Given this list of marker genes FBXO31, SKA3, SYF2, DONSON, BRCC3, NBN, PLK3, ZW10, NABP2, MBTPS2, TIPIN, RAD9A, TREX1, CHEK2, FZR1, INIP, MSH2, ATF2, CLSPN, RPS27L, CCNB1, MAD2L2, LCMT1, MRNIP (NCBI Gene Id 51149), DUSP1, STK33, PLK1, DTL, MRE11, ZNF830, CDK5RAP2, INCENP, SPDL1, TAOK1, SKA1, TRIAP1, TPR, NUF2, CDK5RAP3, NAE1, BUB3, CHFR, BUB1B, SETMAR, UIMC1, WAC, GEN1, RFWD3 (ring finger and WD repeat domain 3), CDC6, ORC1, XPC, APC, PRAP1, CHEK1, RPA2, BRCA1 (BRCA1 DNA repair associated), BRSK1, IER3, TP53, KLHL22, CCND1, SPC25, ZNF207, CDK2, ATM, NABP1, HUS1B, CDC14B, AURKB, ZWILCH, EME2, ANAPC15, ATR, VPS4A, USP44, INTS3, BIRC5, MUC1, BABAM2, CENPF, SDE2, FANCD2, RBBP8, MAP3K20, BLM, ABRAXAS1, SPC24, RINT1, TICRR, RAD17, TAOK3, MAD2L1, KNL1, GIGYF2, MUS81 (MUS81 structure-specific endonuclease subunit), IK, TTK, MDC1, PRP4K, EME1, TAOK2, MAD2L1BP, NOP53, HUS1, ZWINT, NDC80, TRIM39, KNTC1, DYNC1LI1, FOXN3, PABIR1, TOPBP1 (DNA topoisomerase II binding protein 1), RAD9B, BABAM1, DGKZ, TEX14, BUB1, NEK11, BARD1, RAD50, MBTPS1, TRIP13, ETAA1, PPP1R10, CDK1, HASPIN, PSMG2, CDC20, PRKDC, XRCC3, CHMP4C, MAD1L1, FOXO4, CDKN1A, CDCA8, ZFYVE19, here is a description of the gene set: species: Homo sapiens A signaling process that ensures accurate chromosome replication and segregation by preventing progression through a mitotic cell cycle until conditions are suitable for the cell to proceed to the next stage. Human Gene Set: GOBP_MITOTIC_CELL_CYCLE_CHECKPOINT_SIGNALING